Given this list of marker genes Ell2, Siae, Yae1d1 (Yae1 domain containing 1), Dusp22, Rhox13, Pmvk, Irs4, Rhobtb1, Tmem150a, Nr2c2, Prex2, Kdm4a, Nusap1, Stat3, Tomm20, Ppp1r9b, Gnb1, Arpp21, Mfap3l, Ttpa, Lgi4, Gldc, Sorcs1, Ap3m1, Tslp, Sfxn2, Gid4, Greb1, Xirp2, Grm1, Samd4, Ppp1r3b, B230217C12Rik, Lhx9, Sumo2, Bnc1, Vipr1, Dlst, Liph, Slc8a3, Lin9, Dusp16, Col1a2, Gabra1, A830018L16Rik, Itgb3bp, Nfia, here is a description of the gene set: studied in species Mus musculus Mouse Gene Set: MIR_7660_5P Genes predicted to be targets of miRBase v22 microRNA mmu_miR_7660_5p in miRDB v6.0 with MirTarget v4 prediction scores > 80 (high confidence targets). from publication Chen Y, Wang X (PMID 31504780)